Given this list of marker genes CIB2, PIEZO1, FCHSD1, KNCN, SPTBN1, SNX9, CALB1, SPTA1 (NCBI Gene Id 6708), PIEZO2, CALB2, TMC2, here is a description of the gene set: species: Homo sapiens Human Gene Set: GOCC_CUTICULAR_PLATE A dense network of actin filaments found beneath the apical cell surface of hair cells, and into which stereocilia are inserted.